Given this list of marker genes EDN1, CSRNP1, GADD45B, KLF4, MMP9, CTSS, FN1, CXCL2, THBS1, CCN1, BCL6 (NCBI Gene Id 604), IGFBP5, TNFRSF9, C3, PTGS2, PTX3, SERPINA3, PMP22, CDKN1B, HHEX, IL1B, CCL2, PTGER4 (NCBI Gene Id 5734), CCN2, NFKBIA, SULF1, IGFBP3, NUAK2, TPST1, CSF2, JAG1, IL1A, CXCL8, BIRC3, here is a description of the gene set: Genes down-regulated in A375 cells (melanoma) treated with KINK-1, a small molecule inhibitor of NFKB. species: Homo sapiens Human Gene Set: SCHOEN_NFKB_SIGNALING BACKGROUND: Increasing the efficacy of chemotherapeutics by reducing chemoresistance may be a useful strategy in cancer therapy. Constitutive activation of nuclear factor-kappa B (NF-kappaB) is a hallmark of various cancers, including melanoma, which is almost universally resistant to chemotherapy. NF-kappaB is regulated by inhibitory kappaB (IkappaB) proteins, which are in turn phosphorylated by the IkappaB kinase (IKK) complex. METHODS: The effect on NF-kappaB activity of a novel small-molecule inhibitor of the beta subunit of IKK (KINK-1; kinase inhibitor of nuclear factor-kappaB-1) was assessed by measuring phosphorylation of the alpha subunit of IkappaB by immunoblotting, DNA binding by electrophoretic mobility shift assays, and nuclear translocation of NF-kappaB using immunofluorescence. Regulation of NF-kappaB-dependent gene expression was determined by microarray analysis, real-time and semiquantitative reverse transcription polymerase chain reaction (RT-PCR), and Western blot analyses. The effects of KINK-1 (alone and in combination with cytostatic agents) on melanoma cells were characterized by assessing proliferation, soft agar colony formation, and markers of apoptosis. The antitumoral efficacy of KINK-1 in combination with the cytostatic agents doxorubicin or camptothecin (all injected intraperitoneally) was tested in vivo by measuring lung weight and counting metastases in C57BL6 mice (groups of six) bearing metastases of melanoma cells. All statistical tests were two-sided. Results KINK-1 strongly suppressed both constitutive and induced NF-kappaB activity in melanoma cells. It reduced the expression of NF-kappaB-dependent gene products that regulate proliferation, cytokine production, and antiapoptotic responses but exhibited little antiproliferative or proapoptotic activity at the cellular level. However, KINK-1 markedly increased the activities of some cytostatic agents in vitro and abrogated doxorubicin-induced NF-kappaB activation. Combined treatment of C57BL6 mice that had been injected with melanoma cells with KINK-1 and doxorubicin or camptothecin reduced metastases and pulmonary tumor mass compared with either treatment alone (mean lung weight 19 days after injection of melanoma cells of mice treated with 3 mg/kg KINK-1 alone, 1 mg/kg doxorubicin alone, and 1 mg/kg doxorubicin plus 3 mg/kg KINK-1 = 260 mg, 95% confidence interval (CI) = 216 to 305 mg; 268 mg, 95% CI = 224 to 313 mg; and 181 mg, 95% CI = 171 to 192 mg, respectively, P <.001 from t tests comparing mean lung weight of double-treated mice to that in mice treated with either compound alone). CONCLUSION: Inhibition of constitutive and induced IKKbeta-activity through treatment with KINK-1 might increase tumor susceptibility to chemotherapy. from publication Schön M, Wienrich BG, Kneitz S, Sennefelder H, Amschler K, Vöhringer V, Weber O, Stiewe T, Ziegelbauer K, Schön MP (PMID 18544741)